The following is a description of a gene set: Fumarate hydratase-deficient renal cell carcinoma (FH-deficient RCC) is a rare yet highly lethal kidney cancer. To deepen understanding of FH-deficient RCC, the authors conduct a comprehensive integrated genomic study. The authors analyze the association of FH alteration patterns with tumor heterogeneity and develop a CpG site-specific methylation signature for precise identification of FH-deficient RCC. Transcriptomic analysis unveils three distinctive molecular subtypes characterized by enrichment of immune/Angiogenic/Stromal (C1), WNT/Notch/MAPK (C2), and proliferation/stemness (C3) pathways, respectively. Tumors in C1 derive the most substantial survival benefit from a combination of immune checkpoint blockade (ICB) and anti-angiogenic therapy. Tumors in C2 display moderate response to this therapeutic approach. In contrast, tumors in C3 exhibit an unfavorable response to anti-angiogenic monotherapy and its combination with ICB. These findings contribute to a profound understanding of the aggressive nature of FH-deficient RCC, offering insights into potential precision medicine approaches for disease management. Genes downregulated in FH-deficient RCC tumors compared to adjacent normal tissues. studied in species Homo sapiens Human Gene Set: ZHANG_FH_DEFICIENT_RCC_TUMOR_VS_NORMAL_DN from publication Zhang X, Zhao J, Yin X, Liang J, Wang Y, Zheng L, Tan P, Lin Y, Xu N, Zhu S, Chen J, Zhao J, Hu X, Pan X, Nie L, Zhang M, Chen Y, Zhang Y, Liu H, Dai J, Wang Z, Liu H, Ni Y, Rupp NJ, Moch H, Sheng X, Gong K, Liu X, Chen Z, He Z, Wang Y, Xu L, Liu M, Zhou H, Tang B, Huang R, Wei Q, Li X, Liu J, Yao J, Liao B, Liu Z, Shen P, Chen N, Zeng H, Sun G (PMID 40355427), and this is the list of marker genes: ALDH4A1, MLXIPL, ZNF488, SLC34A3, SLC5A2, AVPR2, SPACA1, GRM1, KLF15, MT-CYB, CDH10, HAO2, SLC5A1, CNBD2, KLK7, IQSEC3, SLC22A11, NAGS, ALDH3A1, PLG, COLEC11, FLRT1, CTRB2, GLIS1, CYSRT1, RND2, SLC5A8, GPC5, STPG3, NOL4, ADGRV1 (adhesion G protein-coupled receptor V1), FER1L6, CTRB1, CRB2, FOXRED2, CCN6, PACRG, GKN1, DPP6, TSPAN8, CUBN, HOXB1, RBBP8NL, SPMIP1, FOXN1, KHK, PROM2 (NCBI Gene Id 200480), LRRTM1, TENT5B, ERVMER34-1, MYL3, GRIA3, ABAT, TRPV6, MIOX, RNF223, IGF2BP1, LY6K, TNNT2, MUC13, FMN2, POU3F4, PRSS1, RHBDL3, ADM2, FOLR3, CDHR5, CRYAA, FAM151A, BAIAP2L2, RASSF10, MUCL3, CSDC2, CES3, SPON2, GP2, ANKS4B, CPA1, CAPN12, RBP4, SYT7, ABCC6, GAL3ST2, ESPN, SLC5A10, ATP6V1B1, NHERF4, SPSB4, F12, SLC22A13, PAH, KCNH6, AMPH, SHANK1, EPO, PROZ, CD300LG, SLC5A11, C22orf15, LMX1B, KRT7, SLC39A5, C4orf54, CYP4A22, BPI, AQP7, PRODH, PDILT, GRAMD1B, STAC2, NAT8L, TRPM5, ADRA1A, TRIM50, LYNX1, MAB21L4, ERICH4, PNLIPRP1, MTTP, PNMA5, SYNPO2L, ADAMTS19, KCP, PHYHD1 (phytanoyl-CoA dioxygenase domain containing 1), PTH1R, CDH9, MOGAT3, KIRREL2, NMRK2, AMY2A, SMIM5, SLC16A9, GABRG3, SLC47A1, SARDH (sarcosine dehydrogenase), PRMT8, FUT3, SIM2, AKR7A3, CLEC18A, RGS9BP, MYOM3, KLK1, HECW1, USP2, HCRTR2, NEU4, KLK15, NR0B2, PNPLA3